Given this list of marker genes CHD9, MED1, HDAC3, CRTC3, CLOCK, RORA, TBL1XR1, PPARGC1A (PPARG coactivator 1 alpha), NCOR1, TGS1, CREBBP, RAI1, USP46, RXRA, BMAL1, CARM1, RORB, NRIP1, NCOA6, TBL1X, NCOA2 (NCBI Gene Id 10499), SIRT1, MEF2C, MEF2D, HELZ2, CRTC1, CREB1, NCOA1, RORC, EP300, PPARA, CRTC2, NR1D1, ATF2, NPAS2, SMARCD3, here is a description of the gene set: Expression of BMAL (ARNTL), CLOCK, and NPAS2 Human Gene Set: REACTOME_EXPRESSION_OF_BMAL_ARNTL_CLOCK_AND_NPAS2 studied in species Homo sapiens